The following is a description of a gene set: Human Gene Set: GOMF_METAL_CATION_MONOATOMIC_CATION_ANTIPORTER_ACTIVITY Enables the transfer of a solute or solutes from one side of a membrane to the other according to the reaction: solute(out) + Na+(in) = solute(in) + Na+(out). studied in species Homo sapiens, and this is the list of marker genes: SLC9A5, SLC9C1, SLC4A10, SLC11A1, SLC41A1, SLC38A5, SLC30A5, SLC17A7, SLC24A3, SLC9A4, TMCO3, SLC24A4, SLC9A6, SLC9A8, SLC41A3, SLC8A1, SLC30A1, SLC17A6, SLC9A1, LETM1, GHITM, SLC9C2, SLC9A3, SLC30A2, SLC4A9, SLC9B1, SLC9A2, SLC24A1, SLC30A8, SLC30A6, SLC24A2, SLC9A7, SLC8B1, SLC8A3, SLC24A5, SLC9B2 (NCBI Gene Id 133308), SLC8A2, SLC9A9, SLC30A10, CHP1, SLC38A3, SLC4A8